The following is a description of a gene set: species: Homo sapiens Any process that activates or increases the frequency, rate, or extent of toll-like receptor 9 signaling pathway. Human Gene Set: GOBP_POSITIVE_REGULATION_OF_TOLL_LIKE_RECEPTOR_9_SIGNALING_PATHWAY, and this is the list of marker genes: RTN4, TLR9, HMGB1, ZDHHC3 (zinc finger DHHC-type palmitoyltransferase 3), RSAD2, SLC15A4